The following is a description of a gene set: An abnormal appearance of the midbrain in axial magnetic resonance imaging in which the elongated superior cerebellar peduncles give the midbrain an appearance reminiscent of a molar or wisdom tooth. Human Gene Set: HP_MOLAR_TOOTH_SIGN_ON_MRI species: Homo sapiens Molar tooth sign on MRI, and this is the list of marker genes: B9D1, KIAA0586, TMEM231, PDE6D, CPLANE1, CEP41, CEP120, FAM149B1, OFD1, EXOC2, AHI1, TMEM138, NPHP1, TMEM218, TMEM237, CC2D2A, C2CD3, CEP104, INPP5E, ZNF423, B9D2, SUFU, CEP290, TCTN1, TMEM107, PIBF1, ARL3, CSPP1, IFT74, TCTN3, ARL13B, ARMC9, KIAA0753, TOGARAM1 (TOG array regulator of axonemal microtubules 1), RPGRIP1L, KIF7, MKS1, TOPORS, TMEM67, TMEM216